Given this list of marker genes PTX3, C4BPB, PLA2G5, MBL2, MYO18A, CRP, SPON2, SFTPA1, COLEC10, COLEC11 (collectin subfamily member 11), FCN2, FCN1, C4B, LBP, FCN3, C4BPA, CFP, here is a description of the gene set: studied in species Homo sapiens Human Gene Set: GOBP_OPSONIZATION The process in which a microorganism (or other particulate material) is rendered more susceptible to phagocytosis by coating with an opsonin, a blood serum protein such as a complement component or antibody.